The following is a description of a gene set: STAT3, an essential transcription factor with pleiotropic functions, plays critical roles in the pathogenesis of autoimmunity. Despite recent data linking STAT3 with inflammatory bowel disease, exactly how it contributes to chronic intestinal inflammation is not known. Using a T cell transfer model of colitis we found that STAT3 expression in T cells was essential for the induction of both colitis and systemic inflammation. STAT3 was critical in modulating the balance of T helper 17 (Th17) and regulatory T (Treg) cells, as well as in promoting CD4+ T cell proliferation. We used chromatin immunoprecipitation and massive parallel sequencing (ChIP-Seq) to define the genome-wide targets of STAT3 in CD4+ T cells. We found that STAT3 bound to multiple genes involved in Th17 cell differentiation, cell activation, proliferation and survival, regulating both expression and epigenetic modifications. Thus, STAT3 orchestrates multiple critical aspects of T cell function in inflammation and homeostasis. from publication Durant L, Watford WT, Ramos HL, Laurence A, Vahedi G, Wei L, Takahashi H, Sun HW, Kanno Y, Powrie F, O'Shea JJ (PMID 20493732) Genes up-regulated in CD4 T cells: medium versus TGF beta. studied in species Homo sapiens Human Gene Set: GSE21670_UNTREATED_VS_TGFB_TREATED_CD4_TCELL_UP, and this is the list of marker genes: KIF4A, PLA2G4E, PARP1, RGR, UBE2C, C10orf90, FBXL13, GGT6, RIBC2, CRYAA, MDH1B (malate dehydrogenase 1B), KCNQ1, GPR174, BMP10, INSYN1 (inhibitory synaptic factor 1), OPN1LW, STEAP2, PAMR1, KCNC2, MPP1, CLEC3B, CLDN10, OPRL1, LAMC3, P2RY4, TENT2, PABPC5, SCN2A, NODAL, PPM1E, PDILT, PNLIP, HSPBAP1 (NCBI Gene Id 79663), EFCAB11, ARTN, TMEM117, CHRM3, NDUFA4, MGAT3 (beta-1,4-mannosyl-glycoprotein 4-beta-N-acetylglucosaminyltransferase), RASGRP4, DMRT3, IQCF5, SEL1L3, RAB3B, IKZF1, SPTBN2, C3, RBP3, WNT7B, ECT2, ZYG11A, HBZ, GRIK3, ADRA1A, CDK20, LACTBL1, PLBD1, NECAB2, SCN4B (sodium voltage-gated channel beta subunit 4), SDK1, TACR2, TLR5, VSX1, SPATS1, PRM3, GPAT4, PHLDA3, MAPK10, HSPA8, ASS1, GCM1, ABCA12, DUSP8, BUB1B, C6orf118, GP2, TMC2, MYOG, MZB1, ARHGDIG, LIPI, ADAD2, RTN4RL1, STAC, SCNN1G, SLC25A12, SLITRK5, CAPN8, HCN1, KLK11, IGSF9, IGDCC3, RAD51B, REG3A, ACCSL, DLK1, XRCC6, CCNB3, SGMS2 (sphingomyelin synthase 2), EIF1AD, CD163, HRH1, IL31RA, DMRT2, SNCB, CXCL17, PLEKHS1, KCNJ15, CYLC2, NKX2-5, ALDH3B1, HAPLN4, DTNA, ZDHHC15, EPHA6 (EPH receptor A6), NOS1, LRP2, NOS3, RNF182, ABCD2, DCLRE1C, MORN3, TTC22, DPCD, SH3RF3, SHOX2, KIF23, ZNF385C, LIF (LIF interleukin 6 family cytokine), BLOC1S3, CFAP70, FKBP6, TENM2, UBASH3A, FAM151A, ARHGEF37, FKBP2, SMAD9, CYP4A11, BPIFB2, IQSEC3, CDT1, CEP128, GLB1L, RAB39A, UGT2B15, DNAH17, SAA1, MSGN1, MCHR1, SLC30A8, NTMT2, ZNF750, TMEM184C, CDH18, PCDHB6, RAP2C, DLG5, TTC36, FREM2, MEP1B, FABP4, TEX12, JPH3, KCNJ6, GSDMC, GSTA5, DGKB, CAPNS2, ZNF541, CHRM4, MAT1A, MIS18BP1, RIPK2, SYNDIG1, NR2E1 (NCBI Gene Id 7101), COBL (NCBI Gene Id 23242), SLC30A3, RFX4, CNN3, FAM83G, VAT1L, PHACTR1, ACOT12, CYP2U1, PDGFB, PLIN5, IFITM10, LIPT2, C2orf42, KCNQ4, ALX1, CDKN2B (NCBI Gene Id 1030), TRPC5, DESI1, TEAD1, FOXJ1, DRD2, SLC1A1, MPZL3